The following is a description of a gene set: studied in species Homo sapiens Human Gene Set: GOMF_CELL_ADHESION_MEDIATOR_ACTIVITY The binding by a cell-adhesion protein on a cell surface to an adhesion molecule on another cell surface or an external substrate, to mediate adhesion of the cell to the external substrate or to another cell., and this is the list of marker genes: ITGA9, GLDN, CLSTN3, LRRC4C, ITGA1, MADCAM1, CD200, CNN3, CTNND1, EPCAM, DSC2, DSP, NECTIN3, NRCAM, LAMA5, S100A11, NPTN, CNTN1, JUP, CXADR, PAK4, IGSF9, ROBO3, MCAM, ADGRL3, CD47, NTNG1, PPP1CA, ITGA11, BAIAP2, PDLIM5, MYPN, CNTN2, AGER, NEXN, DSG2, BSG, RAB10, PLXNB3 (NCBI Gene Id 5365), SIRPA, ROBO4, CNTN6, TMIGD1, CLDN3, NECTIN1, CDH5, ANXA1, SVEP1, EMILIN1, PKP2, ESAM, IZUMO1, PDLIM1, STXBP6, RPSA, MIP, TMOD3, CNTN4, DSCAML1 (NCBI Gene Id 57453), NFASC, VCAM1, CNTN5, ITGB1, BCAM, KRT18, ITGA10, TRIM29, PALLD, JAM3, NINJ1, DSCAM, EMB, ANXA2, ITGA2, BAIAP2L1, RPSA2, PKP3, CDC42EP1, CLDN19